Given this list of marker genes MIR24-1, CFDP1, CHD8, STK17B, BTG1, PIK3CA, XRCC2, SFRP1, BBC3 (NCBI Gene Id 27113), BID, PIK3CG (phosphatidylinositol-4,5-bisphosphate 3-kinase catalytic subunit gamma), IER3IP1, GAS6, TP63, NUPR1, TP53, PRDM11, API5, MIR181B1, BCL2L11, STK17A, here is a description of the gene set: species: Homo sapiens Human Gene Set: GOBP_REGULATION_OF_FIBROBLAST_APOPTOTIC_PROCESS Any process that modulates the frequency, rate or extent of fibroblast apoptotic process.